The following is a description of a gene set: Th1 and Th2 cells arise from a common precursor cell in response to triggering through the TCR and cytokine receptors for IL-12 or IL-4. This leads to activation of complex signaling pathways, which are not known in detail. Disturbances in the balance between type 1 and type 2 responses can lead to certain immune-mediated diseases. Thus, it is important to understand how Th1 and Th2 cells are generated. To clarify the mechanisms as to how IL-12 and IL-4 induce Th1 and Th2 differentiation and how TGF-beta can inhibit this process, we have used oligonucleotide arrays to examine the early polarization of Th1 and Th2 cells in the presence and absence of TGF-beta after 0, 2, 6 and 48 hours of polarization. studied in species Homo sapiens Human Gene Set: GSE2770_UNTREATED_VS_IL4_TREATED_ACT_CD4_TCELL_6H_DN Genes down-regulated in CD4 T cells: untreated (0h) versus activated by anti-CD3 and anti-CD28 and then stimulated by IL4 (6h). from publication Lund R, Aittokallio T, Nevalainen O, Lahesmaa R (PMID 14607935), and this is the list of marker genes: ITGB3BP, HIPK3, RAC2, KIF11, LTK, SDE2, PAIP2, SNRPD1, TP53I11, ITGAV, NFATC2IP, HIF1A, SEC22C, PCM1, HLA-DOB, HEATR6, STAG2, CBX7, IFIT2, CD2, INTS6L, POLR3B, PPP6R1, IPO5, PCYT1B, MAP3K3, ZC3H7B, LONRF1, CUX1 (cut like homeobox 1), SUMO3, ORMDL1, NCOA1, HNRNPUL2, ZNF346, ANGPTL1 (angiopoietin like 1), MAPK11, LSP1, C4orf46, EXOC6, GAPVD1, SMCO4, BCAR3, DSN1, EPOP, AGER, SETD1A, TMEFF1, REV3L, TFEB, TBL1XR1, RAP1GDS1, YWHAB, GRB2, RHOF (ras homolog family member F, filopodia associated), PHIP, RPS6KA3, CLIC1, MRPL20-AS1, LIMD1, HSD17B7, PLCG1, VASN, PIF1, B9D2, ACP5, ITPA, AKAP11, CSK, EIF3F, NFATC3 (nuclear factor of activated T cells 3), MAP4K2 (NCBI Gene Id 5871), METTL14, BNIP1, SPSB3, REL, DENND1B, MTBP (MDM2 binding protein), TUSC3 (tumor suppressor candidate 3), NEIL1, GMIP, CDCA3, TCOF1, GCNT1, ACTR6, LIFR, NBEAL2, C16orf87, MBP (myelin basic protein), SPNS3, HERC3, RDH12, UVRAG, AKAP13, CA13, SLC9A5, CELSR1, AHCTF1, PANK2, ECT2, MID1IP1, ZNF367, PXK, MDM1, MBD4, CORO1B, INVS, SH3KBP1, DUS2, THOC7, ESCO2, MFSD1, JAK2, LNX2, FAM168B, PHF2 (PHD finger protein 2), USP1, EEF1AKMT2, DTNBP1, TXNDC16, NIPSNAP1, SNX30, NEK2, HLA-DRB1, PEX7, TOP2B, SULT1A1, SBF2, CBFB, SF3B2, CDKN2D, MAP7, CNST, L3MBTL3, TK2, ITGB3, SPI1, RGS19, RNF125, EID1, MZT1, RABEP1, OAS1, PPP1R3F, PLEKHO2, RPS6KA5, SPEF1, TBCEL, MRPL3, TPD52, C3orf70, GNA13, RPGR, VPS33A, PPP1CA, USP11, B9D1, WIPF1 (WAS/WASL interacting protein family member 1), DNM1L, ADD3, IDH3B, OSGIN2, ROPN1L, KLHDC3, OSBPL9, DTNB, NOXRED1, BID, SDCCAG8, ITPR1, BCL7A, IL4R, C19orf25, SLC39A6, UNC119, PEA15, SLBP, SULF2, IQCE, PHKA1, POLR1D, ATXN7L1, NCOA3, GYPC, SETD2, BTBD6 (BTB domain containing 6), C18orf54, ANKRD11, PTPN23 (protein tyrosine phosphatase non-receptor type 23), RNF41, TEN1, MAD2L1, SCAI, ZC3H14, ZNF746, ARHGAP33, GAB3, N4BP3, ATXN10, GNA12, MAGOHB